The following is a description of a gene set: Human Gene Set: MIR6720_5P from publication Chen Y, Wang X (PMID 31504780) Genes predicted to be targets of miRBase v22 microRNA hsa-miR-6720-5p in miRDB v6.0 with MirTarget v4 prediction scores > 80 (high confidence targets). species: Homo sapiens, and this is the list of marker genes: PHF1, RAP1GAP2, ZMYM2, WDR37 (NCBI Gene Id 22884), TNRC6C, PSME3, SLC12A7, CHSY1, FOXP4, SESN1, KIF16B, SRSF4, KDM5B, DAB2IP, SLCO5A1, NPM1, OR51E2, IRGQ, PIK3C2B, ZNF20, RBFOX2, PDCD4 (NCBI Gene Id 27250), VCAN, EIF2S2, AGPAT1, TSGA10, FCHSD1, NXT2, PNKD, ZC3H12C, SGPP2, JRK, BACE2, LUZP1, CROT, SLAMF1, ADD1, RBPJ, CAMK2A, CEACAM7, TPM1, RSPH10B, NR3C1, MTARC1, ELP6 (elongator acetyltransferase complex subunit 6), LETM1, SLC39A10, ESRRB, UBE2D3, STRADA, ARFGAP2, RCBTB1, SMARCD1, SLC19A3, STON1, CMPK1, MDM4, XRCC3, ZSCAN29, CUL5, EHBP1, LASP1, GPT2, UMPS, KCNK2, SWSAP1, FABP2, BAGE2, GPLD1, AAK1, ZNF180, RAP1GDS1, LRFN1, ZSWIM8, MAGI3, C1QTNF3, CEACAM6, SMAD4, UBE2G1, TRIM8, ENTPD1 (ectonucleoside triphosphate diphosphohydrolase 1), MRPS7, RBMS2, FAAP20, F11R, TRAF4 (NCBI Gene Id 9618), IPCEF1, FGF7 (fibroblast growth factor 7), SH3TC2, CCDC6, STMN4, WWC3, EFCAB2, C1orf21, AKAP12, MYCL, TM6SF1, SALL1, MACIR, PCGF3, ORAI2, ZDHHC2, UBE2Q1, STPG4, PLK2, PSTPIP2 (proline-serine-threonine phosphatase interacting protein 2), AKT3, ARPC2, VPS53, LRIG1, SMCR8, SPTSSB, MSANTD4, METTL13, RNF144A, SDC1, DIP2B, CCDC71L, SHISA6, RSPH10B2, MMP13, ADORA3, ZNF217, IL1RL2, EXO5, DHX36, SLC24A4, OTX2, TMEM88 (transmembrane protein 88), SAMD12, TMEM106C, SULT4A1, NAT9